The following is a description of a gene set: species: Mus musculus Mouse Gene Set: GOBP_REGULATION_OF_EPITHELIAL_CELL_PROLIFERATION Any process that modulates the frequency, rate or extent of epithelial cell proliferation., and this is the list of marker genes: Gata3, Vhl, Nkx2-9, Cyp7b1, Tgfb2, Atf2 (NCBI Gene Id 97033), Azin1, Wfdc1, Yap1, Wdr77, Akt3, Nfib, Zfp580, Prkca, Bad (BCL2-associated agonist of cell death), Mydgf, Tbx1, Men1, Nr2f2, Tbx18, Ccnd2, Mtor (NCBI Gene Id 80612), Bmp4, Erbb2, Ccl2, Tacstd2, Gkn3, Aqp11, Hpn, Zfp703, Nlrc3, Rap1gap, Ifng, Hmga2, Wnt10b, Rida, Pla2g2a, Sav1 (salvador family WW domain containing 1), Serpinf1, Myc, Agap2, Notch2, Ccl11, Rictor, Acvrl1, Dlg1, Sulf1, Kdr, Rb1, Pdx1, Adora2b, Esrp1 (epithelial splicing regulatory protein 1), Cd109, Foxp2, Gas1, Mycn, Bnc1, Cdc25a, Pdgfb, Prkd1, F3 (NCBI Gene Id 99486), Nme2, Aggf1, Dusp10, Tnmd, Plau, Fgf18, Arx, Atp7a, Kif3a (kinesin family member 3A), Srsf6, Plcg1, Birc5, Jcad, Lims1, Ptprn, Epgn, Pdpk1, Prkdc, Itgb3bp, Nras, Rptor, Cav2, Frs2, Bax, Ager (NCBI Gene Id 11596), Ang6, Drd2, Ptn, Bmp5, Hey1, Errfi1, Fgf9, Apoe, Ift57 (NCBI Gene Id 73916, intraflagellar transport 57), Tek, Synj2bp, Ptprm, Cpb2, Pax6, Sox9, Ctsl, Ang4, Ift122, Sparc, Mst1, Fgfr3, Smo, Itga4, Stk4, Gata2, Robo1, Erbb4, Wdr13, Six4, Rtn4, Il6, Phb2, Notch1, Tgfa, Has2, Ppp1r16b, Fmc1, Gpr15lg, Rreb1, Cyba, Agtr1a, Nupr1, Erbb3, Mta3, Btk, Tgm1, Bid, Hmgb2, Adam17, Sema5a, Nkx2-3 (NCBI Gene Id 18089), Runx2, Cdh13, Igf2, Prl, Nfatc1, Hmx2, Eaf2, Zfp36l1, Six1, Eya1, Ang5, Nf1, Col4a3, Odam, Krit1, Rian, Vdr, Mir205, Gja1, Akt1, Iqgap3, Prox1, Ccl24, Plxnb3, Arg1, Stxbp4, Nog, Flt1, Pdcd10, Gli2, Nrarp (Notch-regulated ankyrin repeat protein), Htra1, Foxp1, Tgfbr3, Slurp1, Vegfc (NCBI Gene Id 22341), C5ar1, Fgf7, Slc39a9, Dll4, Ccnd1, Tie1, Zfp36, Nodal, Cdkn2b, Zfas1 (zinc finger, NFX1-type containing 1, antisense RNA 1), Fgfr2, Itpr1, Vegfb, Cdkn1b, Vash2, Xdh, Grn, Aplnr, Hoxa5, Fgf10, Ecm1, Apc, Ccr3 (NCBI Gene Id 12771), Rbpj, Dab2, Cdc73, Cdh1, Lep, S2bpcox16, Map2k5, Trim24, Hras, Fzd7, Dicer1, Egf, Cdk6, Efnb2, Sox11, Irs2, Apln, Nkx3-1 (NCBI Gene Id 18095), Pgr, Stk3, Flt4, Il12a, Osr1, B4galt1, Phip, Npm1, Hmgn1, Id1, Ift88, Foxe3, Cdkn1c, Sp1, Wnt2, Ccl12, Cxadr (NCBI Gene Id 70446), Pax2 (NCBI Gene Id 207129), Ift52, Reg3g, Prok1, Nppb, Cdc42, Sirt6, Runx3, Nkx2-5, Lrg1, Stk11, Xbp1, Mcc, A4gnt (alpha-1,4-N-acetylglucosaminyltransferase), Ang2, Bmyc, Lims2, Cdh3, Ghsr, Reg3a, Stat3, Ovol2, Pygo2, Ppard, Jun (jun proto-oncogene), Apoh, Sgpp2, Alox5, Brca2, Jag1, Hyal1, Hsf1, Pparg (NCBI Gene Id 19016), St8sia1, Itgb3, Wdr48, Med1, Ift80, Ctnnb1, Extl3 (exostosin-like glycosyltransferase 3), Gpbar1, Rgcc, Gpc3, Fgfbp1, Dsc1, Esr2, Dab2ip, Hes1, Ceacam1, Mtss1, Prkd2, Lrp6, Pgf, Ihh, Phox2b, Tnfaip3, Crnn, Kdm5b, Serpinb5, Agtr1b, Fut2, Cxcl12, Irf6, Dlx6, Scn5a, Ift74, Nkx2-6, Sfrp1, Pex2, Cdkn2a, Dbh, Vip, Sox2, Hdac6, Pkhd1, Sfrp2 (NCBI Gene Id 99743), Col18a1, Ift172, Htr2b (5-hydroxytryptamine (serotonin) receptor 2B), Tgfbr1, Nr4a1, Smad3, Fa2h, Twist1, Tcf7l2, Ngfr, Hes5, Dlx5, Ang, Igf1, Kdf1, Tmigd1, Pik3cd, Etv4, Trp63, Mmrn2, Atp5f1a, Gli1, Mmp12, Aldh1a2, Sfn, Sulf2, Intu, Ccl5, Il12b, Flcn, Tacr1, Ednrb, Maged1 (NCBI Gene Id 94275), Pdcd6, Ptprk, Snai2, Hmgb1, Mdk, Ghrl, Dysf, Rgn, Dlk1, Emc10, Tgfb1, Gpx1, Ptch1, Ar, Wnt3a, Gdf5, Celf1, Hspg2, Cxcr3, Nme1, Deaf1, Stat5a, Shh, Pold4, Tinf2, Lama5, Fgf2, Hmox1, Thbs4 (NCBI Gene Id 21828), Fgfr1, Il10, Marveld3, B2m, Ovol1, Wnt7a, Eppk1, Egfr, Tnf, Ccl26, Isl1, Eng, Cdk4, Mef2c, Bcl11b, Egfl7 (NCBI Gene Id 353156), Nr1d1, Gata6, Atp5if1, Suz12, Fgf1, Twist2, Ednra, Jaml, Bmp6, Thbs1, Hlx, Zeb1, Vash1 (vasohibin 1), Nod2, Cnmd, Gdf2, Krt4, Wnt5a, Osr2, Tsc2, Cask, Stat1, Hrh3 (histamine receptor H3), Glul, Uhrf1, Tgfb3, Klf9, Cav1, Il18, Saal1, Egr3, Nr4a3, Vegfa, Reg1, Muc16, Esr1, Pten, Pdcl3, Bmpr1a, Esrp2, Atoh8, Ceacam2 (NCBI Gene Id 26367), Scg2, Apela, Fut1, Sirt1, Cflar, Cldn1, Aimp1